The following is a description of a gene set: studied in species Homo sapiens An anomaly of the hair follicles of the skin that typically presents as small, rough, brown folliculocentric papules distributed over characteristic areas of the skin, particularly the outer-upper arms and thighs. Human Gene Set: HP_KERATOSIS_PILARIS Keratosis pilaris, and this is the list of marker genes: NLRP1, PGM2L1, SMAD4, COL6A1, HEPHL1, SREBF1, MAP2K1, SHOC2, GJA1, SOS2, WNT10A, LRP1, RECQL, COL12A1, BRAF, RAF1, COL6A2, SOS1, GNB2, TRAF7, ODC1, KRT74, TUFT1 (NCBI Gene Id 7286), KRT16, KRT86, ZNF750, MARS1, CARD14, MBTPS2, KDF1, NRAS, FLG, COL6A3, LZTR1, MAP2K2